The following is a description of a gene set: from publication Hill JA, Feuerer M, Tash K, Haxhinasto S, Perez J, Melamed R, Mathis D, Benoist C (PMID 18024188) The transcription factor Foxp3 is usually considered the master regulator for the CD4+CD25+ Human Gene Set: GSE7460_TREG_VS_TCONV_ACT_DN Genes down-regulated in comparsion of ActTreg versus ActCD4 (see Fig. 1 in the paper for details). species: Homo sapiens, and this is the list of marker genes: PTPN22, MCCC2, SLCO3A1, TECR, FPR3, DCP2, SHISA4, PRSS37, ACSS2, ELAVL3, PRG3, PXDC1 (NCBI Gene Id 221749), IL1RL2, EPHA6, BCORL1, AP2A1, BEX1, SUSD1, ALDH5A1, MTARC1, KIFC3, TNFRSF1A, PMVK, DNAJB2, UNC119B, MCOLN2, SIGLEC10, OGDH, ST6GALNAC2, PPOX, CYB5R1 (NCBI Gene Id 51706), RNF157, VWA8, LIX1, KCNK1, UGT3A2, CFAP418, TFR2, GUCY2D, MIA2 (NCBI Gene Id 91818), KCTD21, NECAB3, DPH5, TGFBR2, TBL1X, MZB1, RNASE2, SLPI, IRAG2, NME6, CCDC175, STRC (NCBI Gene Id 1708), RRP12, PXMP4, BPIFA1, WDSUB1, WSCD1, SPEF1, ZDHHC9, CNST, PACRG (parkin coregulated), GPR35, TSPYL2, NPAS3, SEC24C, CNGA1, TTI2, B3GNT9, AIRE, MCTP2, PGBD5, PDE3B, NIPA1, FNDC11, TMEM170A, PLXNB3 (plexin B3), SLC25A51, CCDC25, PROX2, AKT2, MAN1C1, FBXO10, KIF3A, SEC16A (NCBI Gene Id 9919), MGLL, SLC30A4, GTF2I, HOXC13, MERTK, COL15A1, EMB, PDXK, CDYL2, AEBP1, KLHL25, OTULIN, ITGB3, DAP, PIM2, RASGRF2, HECTD4, ACP5, POLRMT, MOB3B, SIPA1L1, MGAT5B, THEMIS, SPRN, TDRD12, METTL9 (NCBI Gene Id 51108), PRSS54, TMEM121, SLC30A7, DIO1 (iodothyronine deiodinase 1), ITK, COL17A1, MSX1, OPN3 (NCBI Gene Id 23596), AGAP2, SH2D5, VARS2, WASHC4, IL4, CEP164, CLEC4E, HS3ST3B1, RHOBTB2, RGS5, SCGN, RASL12, SEPTIN6, TMEM186, FCAMR, MFAP2, DENND11, ALKBH3, CFAP43, HSDL1, VPS26B, SLC9B1, TSPAN5, BTN1A1, AUH, IQCF5, SMAD6, DAPL1, FPGS, STPG1, HOXD11, CYSLTR1, PMFBP1, C1orf21, AGT, DHCR7, ZCWPW2, GDF2, HPCAL1, RNF150, CTNND2, TRIM6, MISFA, CAPZA3, SPHK2, CATSPERG, CAMK2G, TNNT1, FOCAD, TMEM229B, NTAN1, BHLHE41, ASPSCR1, DSE, APPL2, TTLL12, SSPN, APP, RBFA (ribosome binding factor A), SPOCK2, SLC52A3, SLC16A7, BORCS6, EXOSC6, PIK3R5, SLC46A3, CACNA1G, RACK1, ADCY6, EEF2, TEX9, VWA3A, USF2, RPLP0, MTA1, MCM3AP, RNF208, EVI2A, MYO10